The following is a description of a gene set: Human Gene Set: HP_RETINAL_PERFORATION studied in species Homo sapiens Retinal perforation A small hole through the whole thickness of the retina., and this is the list of marker genes: GUCA1A, PRPH2, CTNNB1, ZNF408, BMP4, NDP, HLA-A, FZD4, COL2A1, GUCY2D, LRP5, LRIT3